The following is a description of a gene set: species: Homo sapiens part of: Extracellular matrix organization Reactome Pathway: Invadopodia formation Podosomes and invadopodia are actin-based dynamic protrusions of the plasma membrane of metazoan cells that represent sites of attachment to and degradation of the extracellular matrix (Linder & Kopp 2005, Murphy & Courtneidge 2011). They are characteristically composed of an actin-rich core surrounded by adhesion and scaffolding proteins. Current convention is to use the term podosome for the structures found in normal cells (such as monocytic cells, endothelial cells and smooth muscle cells) and in Src-transformed fibroblasts, and invadopodium for the structures found in cancer cells. The maturation process for podosomes and invadopodia involves the recruitment and activation of multiple pericellular proteases, which facilitates ECM degradation., and this is the list of marker genes: SH3PXD2A, ADAM12, ADAM19, ADAM15